The following is a description of a gene set: A cell aging process stimulated in response to cellular stress, whereby normal cells lose the ability to divide through irreversible cell cycle arrest. Human Gene Set: GOBP_CELLULAR_SENESCENCE studied in species Homo sapiens, and this is the list of marker genes: MIF, SIRT1, SMC6, FZR1, WNT16, ABI3, MIR20B, TP53, ING2, DNAJA3, RSL1D1, MIR590, SUV39H1, COMP, TP63, BRCA2, ZKSCAN3, CDK2, MIR34A, MNT, NPM1, KIR2DL4, FBXO4, MIR10A, WRN, ZNF277, KRAS, SIRT6, TBX3, HMGA1, MAPK9, MAP2K3, CDK6, NUAK1, ABL1, MAPK11, EEF1E1, TWIST1, MIR146A, B2M, MAGEA2, TOP2B, CDKN2A (NCBI Gene Id 1029), PRKCD, NSMCE2, MIR543, MAP3K5 (NCBI Gene Id 4217), PLK2, CITED2, HLA-G, PAWR, KAT5, YPEL3, BCL6, TERF2, MAPK10 (NCBI Gene Id 5602), MAPK14, MORC3, CDKN1A, MAPKAPK5, NEK4, MIR22 (microRNA 22), HMGA2, LMNA, NUP62, MAP2K7, CGAS, MAP2K4, TERC, PLA2R1, RBL1, BMPR1A, PRMT6, CDKN1B, YBX1, ARG2, KAT6A, SRF, TBX2, BMAL1, SPI1, PRELP, OPA1, ATM, PTEN, MAP2K6, GINS3, AKT3, PNPT1, VASH1, MAP2K1, ULK3, MIR17, FBXO5, ZMIZ1, ID2, WNT1, MAPK8, BCL2L12 (BCL2 like 12), MAGEA2B, TERT, PML, NEK6, ZMPSTE24, HRAS, CALR, ECRG4, CDKN2B, NDUFS6, SMC5, MIR217